The following is a description of a gene set: part of: Defects of Coagulation cascade Reactome Pathway: Defective FV causes thrombophilia studied in species Homo sapiens, and this is the list of marker genes: F5, PROS1, PROC